The following is a description of a gene set: A region of a chromosome at which a DNA double-strand break has occurred. DNA damage signaling and repair proteins accumulate at the lesion to respond to the damage and repair the DNA to form a continuous DNA helix. Mouse Gene Set: GOCC_SITE_OF_DOUBLE_STRAND_BREAK species: Mus musculus, and this is the list of marker genes: Rbbp8, Arpc1a, Shld3, Aplf, Arpc2 (NCBI Gene Id 76709), Lmna (lamin A), Pnkp, Inip, Nbn, Esco2, Actr2, Slf2, Rhno1, Actr3, Dynll1, Was, Sirt6, Kat5, Asf1a, Polh, Tonsl, Peli1, Arpc3, Zbtb7a, Rad51, Atm, Atf2, Nabp2, Helb, Smarcad1, Rif1, Topbp1, Nhej1, Paxx, Htatsf1, Rnf138, Phf1, Smarcal1, Poll, Uimc1, Cntd1, Rnf169, Smchd1, Arpc5, Stk38, Mbtd1, Setmar, Trp53bp1, Iffo1, Arpc4, Mre11a, Parp1, Sirt7, Ufl1, Shld2, Chd1l, Rnf168, Smarca5, Vcp, Dmc1, Smc6, Rad50, Rnf138rt1, Wrap53, Brme1, Prpf19, Smc5, Hus1b, Mdc1, Xrcc4, Rad17, Shld1, Ddb1, Polq, Mms22l, Aim2, Cyren, H2ax (H2A.X variant histone), Cgas, Wdr70, Rpa2, Fh1, Kdm4d, Rad18, Parp3, Trp53, Rfwd3, Epc1, Nabp1, Hus1, Slf1, Timeless, Rpa1, Rnf8, Ints3, Rpa3, Samhd1, Mad2l2